Given this list of marker genes FOXO1, TIMM50, LRPPRC, RPS6, CCDC167, RXRA, TMCC2, FLOT2, CLSTN1, TREML1, HLCS, MRPL38, NDUFS3, ARRB1, GAS5, SRP72, SLC9A3-AS1, RPL4, FAM20C, NDUFB10, ANAPC1, STX10 (NCBI Gene Id 8677), HCG11, RPS5, PTOV1, PTRHD1, ATP5PB, RPL5, MRPL36, NEURL2, RPL7, B3GALT5-AS1, HOXD9, SYNCRIP (synaptotagmin binding cytoplasmic RNA interacting protein), UTP11, RHOT2, TIMM44, MTFP1, TMED3, EIF3L, RPL34, SORT1, PRMT1, SUCLG1, DCTPP1, MRPS2, ARMC7, TBXAS1, TMEM117, MRPL12, MRPS24, UBE2G2, IL17RA, MRPL24, FH, OSTC, SLC37A2, EXOSC2, GPX3, RAB3A, CCDC124, IPO5, TIMM17A, SND1, RPL26, NDRG2, MRPS35, LINC00692, HACD3, RPL13A (NCBI Gene Id 94020), ARL6IP4, GPD1L, DCTN2, UGGT1, LRRC8A, SPDYE1, TIMMDC1, PRORP, GYPC (NCBI Gene Id 2995), RPS10P5, CNIH2, TIMM21, OXA1L, BPNT2 (3'(2'), 5'-bisphosphate nucleotidase 2), SEC61B, HVCN1, MRPS34, TFB2M, SNHG29, GGCT, FBL, S100A9, MMS19, APBA1, SPATC1L, RPL29, MRPL4, TPM1, RPS2, IDH3B, LRRC45, CFAP298, ATP6V0E2, RPL8, TCP1, RNF167, ENHO, PES1 (pescadillo ribosomal biogenesis factor 1), FASTKD1, ATP5MG, ASAP2, MRPL48, CCND2, RAB1B, DGAT1, COX6C (NCBI Gene Id 1345), RPS7, VDAC2, MAP1A (microtubule associated protein 1A), NBEAL2, TOP1MT, PREX1, SIRT2, SLC25A6, HIGD2A, MRPS27, GTF3C2, CHD4, NOP53, RPL13, EEF1E1, RPS17, IL16, DMAC1 (NCBI Gene Id 90871, distal membrane arm assembly component 1), OVOL3, FLNA, RPL7A, ACTR1B, RPSA, NRGN, APEX1, KCTD5, MTMR9LP (NCBI Gene Id 651480), DPH2, POLD2, FXN, DDB1, RACK1, RNF151, ZNF219, PABPC4, COX5B, EIF3K, RPL3, LMNB2, MEA1, ATP5F1A, SLC25A29, RPS3, SNRPD2, GPR35, RPL22, LAGE3, EIF2D, CDRT15, UQCRH, TMEM223, MAPKAPK5-AS1, SLC39A4, EEF1B2, ADISSP, ANTKMT, PRKDC, ALG8 (ALG8 alpha-1,3-glucosyltransferase), PPARGC1B, SLAMF8, SET, TTC19, VASH1, JAKMIP3, AURKAIP1, NUP210, IMPDH2, NUDT14, NDC1, ZNF584, DZIP1, ATP5PF, DOCK3, FBRSL1, RPL15, MOCS2 (NCBI Gene Id 4338), TMEM147, PFKM, RABEPK, TMEM161A, CPPED1, POLR2B, R3HCC1, here is a description of the gene set: species: Homo sapiens The recent discovery of the human B1 cells, identified by the expression of CD20, CD27 and CD43 in absence of expression of CD70 and CD69 has been subject of debate. Some studies have raised the possibility that these cells are B cells differentiating towards the plasmablast and plasma cell stage rather than being the human counterpart of murine B1 cells. No further in depth studies have been performed. Therefore, a functional comparison was made between, the proposed B1 cells and plasmablasts. We observed that for several functional characteristics (distribution of isotypes of spontaneously producted antibodies, production of antigen-specific antibodies after vaccination with both T-cell dependent as well as T-cell independent antigen, the proposed B1 cells behaved similar to plasmablasts. In addition, we were able to differentiate the proposed B1 cells in vitro, indicating that they are not from a distinct lineage as the murine B1 cells. Gene expression analysis revealed that these cells cluster between memory B cells and plasmablasts, contradicting them being the genuine human counterpart of murine B1 cells, rather revealing a preplasmablast phenotype. from publication Covens K, Verbinnen B, Geukens N, Meyts I, Schuit F, Van Lommel L, Jacquemin M, Bossuyt X (PMID 23613519) Human Gene Set: GSE42724_NAIVE_VS_B1_BCELL_DN Genes down-regulated in B lymphocytes: naïve versus B1.